The following is a description of a gene set: Any process that activates or increases the frequency, rate or extent of lymphocyte death by apoptotic process. studied in species Mus musculus Mouse Gene Set: GOBP_POSITIVE_REGULATION_OF_LYMPHOCYTE_APOPTOTIC_PROCESS, and this is the list of marker genes: Tgfb2, Siglec1, Prelid1, Bax, Il10, Myc (NCBI Gene Id 17869), Ccl5, Cd274, Cd24a, Trp53, Pdcd1, Fnip1, P2rx7, Perp, Zc3h8, Cd47, Wnt5a, Adam8, Nfkbid, Bbc3, Ido1 (indoleamine 2,3-dioxygenase 1), Pdcd7, Bcl2l11